Given this list of marker genes PI15, GLS, BMPER (NCBI Gene Id 168667), CNTN1, FBXO45, FAM3C, TGFB3, KLHDC2, SOS2, DACT1, FOXO1, SEMA3C, HSPA14, TMED7, AASDH, CTR9, TMEM132B, USP25, HIC1, SEPTIN9, ITM2C, CEP41, FRS2, RAB11FIP3 (NCBI Gene Id 9727), NUDT12, EIF1AD, FBXO33 (F-box protein 33), LAMP2, TSHZ3, FBXO34 (F-box protein 34), KDM7A, IREB2, GIGYF2, AUTS2, BAG2, JAG2, ZNF518B (NCBI Gene Id 85460), GNAQ, WWC1, SELENOK, KDM2B (lysine demethylase 2B), SPRY1, ERF, UBXN7, ELAVL2, UBL3, JAK2, SEPHS1, HS6ST2, GSK3B, KBTBD7, CPEB3, HNRNPA2B1, ACVR1, CLDN16, FUT9, N4BP2, SNAPC1, CTU2, GRM5, SOX9, MLLT10, LIN9, DCC, HIVEP2, MED14, MMS22L, CPEB2, IKZF2, PIK3C2A, DENND2B, MINDY3, KIAA1217, PLAG1, GATA3, CLASP2, LYPLAL1, RBM12B, AKAP9, FSHB, ACVR2B, MECOM, BCL6, SLC6A14, UTRN, WDR26, NPY, MARCHF6, IPMK, ISM1, SPEN, RIMKLB, BTNL9 (NCBI Gene Id 153579), DENND1B, LRCH4, MMAB, LRRC4, KPNA3, HIPK3, STK38L, RPRD1B, RHOA, SLC18A2, SPAST, AMMECR1, CLOCK, PRPF38B, RICTOR, PRKAA1, PLEKHA6 (pleckstrin homology domain containing A6), EIF4G3, HEATR5B, AKAP13, SNCAIP, BHLHE40, GRK5, JPH1, PSD3, GRM3, CDK19, CEP76, AKTIP, SHOC2, RELCH, PDE10A, LCOR, INO80D, ANK3, TRPM7, NGDN, RNF24, NKTR, MED6, PPP1R2, CCDC102B, ARHGEF28, TBC1D2B, CYP7B1, SLC34A2, TAF4B, ZFPM2, SCN7A, ASB11, KRBOX4, ZC3H11A, EIF4A2, PIAS1, ATRX, RNF138, ZNF430, EPHB4 (EPH receptor B4), KMT2C, MAN1A1, RALGDS, CACNA2D1, MEF2C, PAXBP1, USP32, BTF3L4, AKAP6, BASP1, MTARC1, SPTB, IGFBP1, AFF3 (NCBI Gene Id 3899), NOL4, RAB6B, HTR2A, WWC2, ASAP2, MIF4GD, NFYB, FYTTD1, CCNY, KIN, FAM117B, ZNF569, IGF1R, BTAF1, DKK3, TMEM87A, FGFR2, NCOA2, PPM1D, CAB39, PLCL2, USP12, GNB4, C1QBP, FOXP1, CTNNB1, ANKRD44, STK24, HIP1, LIN54, SDHAF3, COL19A1, OTX2, ANO4, RDX, PPP1R21, YTHDC1, CEMIP2, FOXN2, DYNC2LI1, BCAP29, GPRIN3, YY1 (NCBI Gene Id 7528), ANAPC13, TAFA4, UBQLN1, EEA1, APP, GNAL, TLE4, RHOT1, USP24, OLIG3, AP1S3, CMPK1, NUP98, F2RL1, HECTD2, SORBS1 (NCBI Gene Id 80057), CECR2, GUCY1B1, UBN2, CNOT6L, KIAA0408, U2SURP (NCBI Gene Id 23350), THRB, CHD1, ADRB2, KLHL2, RFC3, PCDH8, AHR, L3HYPDH, VAPA, TRIM63, NR3C1, NF1, SEC22C, EDIL3, LRRTM4, COG7, CDH20, ARAP2, ARID4B, C7orf57, HYCC2, BLOC1S4 (biogenesis of lysosomal organelles complex 1 subunit 4), DMTF1, RABGGTB, RIPPLY2, FBN1, DCUN1D4, EMP2, XPO1, EBF3, ACBD3, CALN1, TIGD7, ZNF236, MAPKAPK5, CTTNBP2NL, CWC22, SH3GL3, ZNF326, REV3L, ZNF506, BDNF, LY75, SRSF11, E2F5, UBTF, CARF, EIF4ENIF1, PPP1R3F, LATS1, TAOK1, RAB6D, GNA13, ACTL6A, TRIM6, ARHGEF33, ACTR3, SCARF1, FA2H, TGFBR3, SLC39A10, PHIP, TLE1, SLC6A17, FLT3LG, AKAP12, CD38, NASP, SLC6A11, ZNF367, CEPT1, ARIH1, CORO1C, AAK1, TAS2R14, PEX5L, RBM22, MPC2 (mitochondrial pyruvate carrier 2), ZNF780A (zinc finger protein 780A), VEZF1, ZMIZ1, HECTD1, SALL3, CASP8AP2, PPP3CA, PRRC1, RBPJ, C1QTNF7, PFKFB3, DPM1, FBXL3, GPR158, THAP12, FRMD4B, ARID1B (NCBI Gene Id 645070), DCAF7, NAA25 (NCBI Gene Id 80018), OXR1, ETS2, MATN2 (matrilin 2), IRX3, HNRNPD, CCDC186, LRP6, PRR12, NUFIP2, SV2B, EFNB1, OTUD6B, RAB11B, SET, LIPG, COL1A2, CUL1, MLLT6, PIKFYVE, PAN3, COL4A1, QKI, MBNL2, MSANTD2, NUDT4, PTER, PECR, DCAF6, RHOBTB3, TRGC1, KLF3, FBLN5, NBEA, IMPACT, ITGAV, RASEF, RIF1, SCAMP1, SDC2, ELOVL7, PPP4R2, B3GLCT, PNISR, JAG1 (NCBI Gene Id 3715), PCSK2, ITCH, SLC6A4, PTPRE, ARHGAP20, ULBP1, PHC3, POLR2K, KCNJ15, MAP2, CILK1, UBE2B, HOXA9, SGTB, RORA, CEP192, BRF2, BAZ1B, C18orf63, ATL1, TASP1, BRWD3, PDLIM5, DOCK10, TCERG1L, SLC4A5, PIK3R4, UBR1, FNDC3B, CACNA1C (calcium voltage-gated channel subunit alpha1 C), RFX1, RNF149, SUN1, GTF2I, WNT5B, PANK3, ATP6V1H, PPP4R3B, PSIP1, WASF3 (NCBI Gene Id 10810), ERI1, DLL1, PPM1L (protein phosphatase, Mg2+/Mn2+ dependent 1L), TNS3, MNX1, MALT1 (NCBI Gene Id 10892), APOOL, STON2, NRBF2, ALDH1L2, TET3, C5orf58, SPESP1, TRHDE (thyrotropin releasing hormone degrading enzyme), PARD6B, ZMYM4, LGALSL, KRAS, ARHGAP12, NEUROG2 (NCBI Gene Id 63973), ATG2B, NR4A3, MMP20, MAGI1, NUP35, PRDM16, CCDC126, UBE3C, TRAK1, ZIC1, DCLRE1B, NRP1, CERT1, SCAI, BST1, VCL, GNAI3, CRISPLD1, STK40, GTF3C3, GDAP1, CIAO2A (NCBI Gene Id 84191), ZFYVE16, UBE2W, RAB2A, TVP23B, SPINDOC, PPP1R15B, DNALI1, MYCN, POU2AF3, VMA21 (vacuolar ATPase assembly factor VMA21), SRSF2, SRBD1, BMPR2, TOB1, GTF2A1, OPA1, ELK4 (NCBI Gene Id 2005), SCX, GPR37, ACTR3C, ALKBH8, GOLGA2, ULK1, NECTIN1, CLIP1 (CAP-Gly domain containing linker protein 1), KIF3A, FAM76B, DNAJB5, HOOK3, PLPP3, SPOPL, MAST4, CNOT6, FAM204A, GDAP2, CRY1, AKAP10, RAPH1, FGD6, HERC2, PHYHIPL, FRMD6 (NCBI Gene Id 122786), PEAK1 (pseudopodium enriched atypical kinase 1), BLTP1, LRRC32, DCBLD2, PSD2, C11orf58, DOCK11, DCLK3 (doublecortin like kinase 3), TCF20, PDZRN3, PRDM2, NRP2, RNF180, LRRC1, PPFIA2 (NCBI Gene Id 8499), TFRC, ROCK1, TCF3, ATAD5, MEX3B, GP1BA, NDC1, SAMD12, GABRG1, SOWAHC, NPY1R, CENPE, KIF11, CCL7, TET2, CHD3, GRIA3, SGO1, SPOCK3, ZNF302, NADK2, B3GNT2, SYF2, ZFYVE21 (zinc finger FYVE-type containing 21), WIPI1, RC3H1, FNDC3A, HYCC1, LEMD3, MAP2K3, HNRNPA1, MBNL1, PUM1, ZNF800, ELOVL2, FAT3, FBXO43, KLF2, PUM2, ANO5, RAD21, SMARCA5, APPL1, RAB10, SPRY2, LYSMD3, TRA2A, LHFPL3, TEAD1, ZFY, RAB11FIP2, CREBRF, FSCN1, BTBD3, ZMYM6, SBF2, RPRD1A, LSM14A, CADM1, MRPL44 (NCBI Gene Id 65080), RTN1, LIX1L, SLC2A13, KIF2A, TVP23C, PAK2, CEP57, PARPBP, ZBTB39, KLF4, NAA20, EFR3A, UBE2H, GOLIM4, CDC7, UBN1, RAB3GAP2, POU4F2, PRPF8, TTF2 (NCBI Gene Id 8458), SATB1, FREM2 (NCBI Gene Id 341640), NUP58 (NCBI Gene Id 9818), SP8, ZNF827, HNRNPA1L2, CPNE2, RPS16, CLDN1, MEF2D, DERL1, NR5A2, TM4SF4, DAAM1 (dishevelled associated activator of morphogenesis 1), OTUD4, NFAT5 (nuclear factor of activated T cells 5), PHACTR2, GRHL3, UNC119B, ITM2B, PTCH1, CAMTA1, ZBTB14, YTHDF3, DOP1A, DUSP6, CFTR, DLL4, UBE2Q2, FSTL5, NCKAP1, LILRA1, DR1, KIF21A (kinesin family member 21A), SP4, NTN4, ARHGAP44, BRD1, EGFL6, CCNE2, TMTC2, SLC39A6, DENND4A, POLR1F, USF3, DSG2, CLDN12, ZNF292, TSLP, WAC, PTMS, C11orf54, MBLAC2, RAB14, BMAL1, LRP1B, MARK1, MYCBP2 (NCBI Gene Id 55685), COL11A1, OLFML2B, SPRED1, SECISBP2L, CCNA2, KDM6A, ABI1, GULP1 (GULP PTB domain containing engulfment adaptor 1), ZDHHC20, SFPQ, DOCK1, SMARCA2, LTN1, RSRP1, GLCCI1, NLGN1, IER5, SLAIN2, IFT70A (intraflagellar transport 70A), CNNM4, KLF12, ID4, DDX21, FZD6, DNPEP, TMTC4, CRACD, TAF2, E2F8, SLC35A3, TBR1, HES1, ADAM28 (NCBI Gene Id 27337), ATF2 (NCBI Gene Id 1386), RSF1, FGF7, SCN2A, DACH1, ICE1, SRSF1 (NCBI Gene Id 650453), HMGXB4, PPM1A, MTF1, BRIP1, MON2, CREBZF, PALS2, AGTR1, VAV3, DGKH, USP34 (NCBI Gene Id 9736), ZMYND8 (zinc finger MYND-type containing 8), DLX2, EPS15L1, BMP3, F3, FNBP4, NUDT11, NAA16, ITGA6, PTBP3, TUT4, SYNGR3, ASAH1, HMGCR, ID1, ARID4A, ARFGEF2, UBFD1, MYT1L, NR2F2, RNF216, LGR4, here is a description of the gene set: Genes predicted to be targets of miRBase v22 microRNA hsa-let-7f-1-3p in miRDB v6.0 with MirTarget v4 prediction scores > 80 (high confidence targets). Human Gene Set: LET_7F_1_3P from publication Chen Y, Wang X (PMID 31504780) studied in species Homo sapiens